Given this list of marker genes Alox5ap, Pon1, Pon2, Ltc4s, Pon3, Alox5, here is a description of the gene set: studied in species Mus musculus Mouse Gene Set: REACTOME_SYNTHESIS_OF_5_EICOSATETRAENOIC_ACIDS Synthesis of 5-eicosatetraenoic acids